Given this list of marker genes Dera, Aldoart2, Armt1, Aldoc, Aldob, Aldoart1, Aldoa, Tha1, Shmt1, Shmt2, Sgpl1, Hacl1, here is a description of the gene set: studied in species Mus musculus Catalysis of the cleavage of a C-C bond in a molecule containing a hydroxyl group and a carbonyl group to form two smaller molecules, each being an aldehyde or a ketone. Mouse Gene Set: GOMF_ALDEHYDE_LYASE_ACTIVITY